Given this list of marker genes RAB23, UFM1, SUFU, CHP1, ANGPT1, YWHAB, NF1, EI24 (NCBI Gene Id 9538), CABP1, PKIA, MDFIC, CD36, NFKBIA, SUMO1, SIRT6 (NCBI Gene Id 51548), PKIG, FERMT1, APOD, here is a description of the gene set: studied in species Homo sapiens Human Gene Set: GOBP_NEGATIVE_REGULATION_OF_PROTEIN_IMPORT_INTO_NUCLEUS Any process that stops, prevents, or reduces the frequency, rate or extent of the movement of proteins from the cytoplasm into the nucleus.